Given this list of marker genes Slc38a3, Slc7a8, Slc15a4, Slc7a1, Slc7a5, Slc38a5, Slc3a2 (NCBI Gene Id 17254), Slc36a4, Slc16a10, Slc25a29, Slc66a1, Ace2, here is a description of the gene set: species: Mus musculus Mouse Gene Set: GOBP_AROMATIC_AMINO_ACID_TRANSPORT The directed movement of aromatic amino acids, amino acids with aromatic ring, into, out of or within a cell, or between cells, by means of some agent such as a transporter or pore.